The following is a description of a gene set: Mouse Gene Set: GOCC_ACROSOMAL_VESICLE studied in species Mus musculus A structure in the head of a spermatozoon that contains acid hydrolases, and is concerned with the breakdown of the outer membrane of the ovum during fertilization. It lies just beneath the plasma membrane and is derived from the lysosome., and this is the list of marker genes: Cabs1, Ctnna1, Arsa, Rnd2, Morn2, Knl1, Spata16, Stk31, Spag6, Acrv1, Ncf2, Cep131, Gnat3, Ctsh, Spaca5, Trim36, Rab2a, Tcp11x2, Glipr1l1, Slxl1, Pkdrej, Gm14569, Scnn1a, Actrt1, Prkaca, Ift88, Skil, Mfge8, Spag6l, Fndc3a, Abhd2 (abhydrolase domain containing 2), Klk1b4, Pla1a (NCBI Gene Id 85031), Spag17, Spaca4, Prss55, Spaca6, Racgap1, Tssk2, Fabp9, Ssh2, Tmprss12, Tsks, Atp6v0a2, Bsg, Tsc22d4, Capza3, Tbxa2r, Syt8, Adam15, Cfap119, Rcbtb2, Tssk4, Tssk1, Prss40, Hyal5, Vezt (vezatin, adherens junctions transmembrane protein), Kcnj11, Fam170b, Cct6a, Mroh2b (NCBI Gene Id 74655), Eppin, Ica1l, Klk1, Itga1, Vps13b, Abcc9, Klk1b26, Bmf, Osbp2, Pdia3, Ccdc136, Klk1b21, Rab2b, Klk1b16, Spag8, Cyp51, Pla2g10, Tcp1, Ppfia3, Tmem225, Ift74, Cylc1, Csnk2a2, Dynlt4, Kit, Nudt1 (nudix hydrolase 1), Slc2a3, Iqcf1, Prss37, Pomt1, Atp6v1e2, Slc9a8, Tuba8, Ift20, Cav2, Fsip1, Sun1, Trip11, Flot2, Pramel1, Tmem210, Acr, Klk1b24, Cfap65, Spesp1, Septin14, Klk1b8, Zp3r, Rab3a, Il4i1, Akap3, Spata31, Tmem95, Calcr (NCBI Gene Id 209117), Snapin, Ct55, Dld, Vdac2, Spaca7, Notch1, Fam220a, Klk1b3, Klk1b1, Calr, Zpbp, Tex101, Ace3, Tbc1d21, Enkur, Ccdc62, Klk1b9, Drd2, Stx1a, Cxadr, Dcst2, Cav1, Spag11a, Cd46, Ly6k, Actl7a, Morn3, Lyzl4, Catsper3, Dpep3, Itgb1, Omp, Loxl1, Iqub, Cimip4, Pcsk4, Spata1, Serpina5, Tekt3, Semg1, Spam1, Tex22, Prss39, Creb3l4, Tmem190, Klk1b11, Lypd4, Tcp11, Lyzl6, Dcst1, Dnajb3, Pate4, Acrbp (NCBI Gene Id 54137), Sv2b, Capn11, Usp8, Clk3, Actl9, Klk1b22, Zpbp2 (NCBI Gene Id 69929), Dkkl1, Klk1b5, Hexb, Atp8b3, Lrguk, Crcp, Slirp (NCBI Gene Id 69144), Catsper4, Rab6a, Klk1b27, Spaca1, Eqtn (equatorin, sperm acrosome associated), Adam2, Golga1 (golgin A1), Prkg1, Txndc8, Hyal3, Sh3gl3, Defb22, Izumo3, Atp8b5, Arc, Spink2, Spaca9, Cypt1, Try5 (trypsin 5), Spaca3, Izumo1